Given this list of marker genes SOCS4, IRX1 (NCBI Gene Id 79192), PCSK1N, OSBPL3 (NCBI Gene Id 26031), FBLN5, SOX17, FRMD6, MAGEB2, DDIT4L, WNT2B (NCBI Gene Id 7482), KIT, ELAVL2, XIST, PRAME, GIP, TDRD12, PDPN (podoplanin), TUBBP5 (NCBI Gene Id 643224), KCNV2, DMD, CPEB1, SLC43A1, KHDC3L, TCL1A, RBM24, here is a description of the gene set: Top 25 most highly expressed genes in seminoma relative to embryonic carcinoma tumors. from publication Korkola JE, Houldsworth J, Chadalavada RS, Olshen AB, Dobrzynski D, Reuter VE, Bosl GJ, Chaganti RS (PMID 16424014) Human Gene Set: KORKOLA_EMBRYONIC_CARCINOMA_VS_SEMINOMA_DN studied in species Homo sapiens Adult male germ cell tumors (GCTs) comprise distinct groups: seminomas and nonseminomas, which include pluripotent embryonal carcinomas as well as other histologic subtypes exhibiting various stages of differentiation. Almost all GCTs show 12p gain, but the target genes have not been clearly defined. To identify 12p target genes, we examined Affymetrix (Santa Clara, CA) U133A+B microarray ( approximately 83% coverage of 12p genes) expression profiles of 17 seminomas, 84 nonseminoma GCTs, and 5 normal testis samples. Seventy-three genes on 12p were significantly overexpressed, including GLUT3 and REA (overexpressed in all GCTs) and CCND2 and FLJ22028 (overexpressed in all GCTs, except choriocarcinomas). We characterized a 200-kb gene cluster at 12p13.31 that exhibited coordinated overexpression in embryonal carcinomas and seminomas, which included the known stem cell genes NANOG, STELLA, and GDF3 and two previously uncharacterized genes. A search for other coordinately regulated genomic clusters of stem cell genes did not reveal any genomic regions similar to that at 12p13.31. Comparison of embryonal carcinoma with seminomas revealed relative overexpression of several stem cell-associated genes in embryonal carcinoma, including several core stemness genes (EBAF, TDGF1, and SOX2) and several downstream targets of WNT, NODAL, and FGF signaling (FGF4, NODAL, and ZFP42). Our results indicate that 12p gain is a functionally relevant change leading to activation of proliferation and reestablishment/maintenance of stem cell function through activation of key stem cell genes. Furthermore, the differential expression of core stem cell genes may explain the differences in pluripotency between embryonal carcinomas and seminomas.